Given this list of marker genes Inhbb, Inhba, Pcsk1, Inhbc, Fshb, Cga, Pomc, here is a description of the gene set: Reactome Pathway: Peptide hormone biosynthesis This event has been computationally inferred from an event that has been demonstrated in another species.<p>The inference is based on the homology mapping from PANTHER. Briefly, reactions for which all involved PhysicalEntities (in input, output and catalyst) have a mapped orthologue/paralogue (for complexes at least 75% of components must have a mapping) are inferred to the other species. electronically inferred by orthology from the curated human pathway part of: Peptide hormone metabolism studied in species Mus musculus